The following is a description of a gene set: Genes down-regulated in peripheral blood mononuclear cell 3d vs 0d in adults (18-50) after exposure to Fluarix/Fluvirin, time point 3D. Comment: Supplementary Table 1a: All the differentially expressed genes identified in PBMCs of TIV vaccinees. from publication Nakaya HI, Wrammert J, Lee EK, Racioppi L, Marie-Kunze S, Haining WN, Means AR, Kasturi SP, Khan N, Li GM, McCausland M, Kanchan V, Kokko KE, Li S, Elbein R, Mehta AK, Aderem A, Subbarao K, Ahmed R, Pulendran B (PMID 21743478) species: Homo sapiens Here we have used a systems biology approach to study innate and adaptive responses to vaccination against influenza in humans during three consecutive influenza seasons. We studied healthy adults vaccinated with trivalent inactivated influenza vaccine (TIV) or live attenuated influenza vaccine (LAIV). TIV induced higher antibody titers and more plasmablasts than LAIV did. In subjects vaccinated with TIV, early molecular signatures correlated with and could be used to accurately predict later antibody titers in two independent trials. Notably, expression of the kinase CaMKIV at day 3 was inversely correlated with later antibody titers. Vaccination of CaMKIV-deficient mice with TIV induced enhanced antigen-specific antibody titers, which demonstrated an unappreciated role for CaMKIV in the regulation of antibody responses. Thus, systems approaches can be used to predict immunogenicity and provide new mechanistic insights about vaccines. Human Gene Set: NAKAYA_PBMC_FLUARIX_FLUVIRIN_AGE_18_50YO_3DY_DN, and this is the list of marker genes: RHOH, MYLIP, MSI2, MDH1, SLC2A14, MEF2D, SGSM2, SYTL3, GOLGA8A, CXorf65, ATL2, UBE2B, SELENOK, RNF103, OSER1, RAD23B, BCLAF1, ITPKB, ZBTB25, GOLGA8B, RACK1, ATG16L1, PPP2CA, GORAB, SCAF11, GOLGA6L9, NUP58, CD6, RANBP2, SMURF1, USP15, GNL1, BTG3, BMAL1, ZBTB43, VCPKMT, ILKAP, RGPD8, CDKN1B, PCNX1, RBM25, WDR26, CCNL2, U2AF1, CLK1, RAB11FIP2, COPA, TENT4A, GTF2B, MOAP1, SENP3, ATG2A, CCNL1, ITPR1, PARP8, DIP2B, TASOR2, NOL11, MPHOSPH8, RUNX2, PHF3, FUS, UBAP2L, ZBTB7A, ARID5A, TRIM13, KLHDC2, RGPD5, KANSL2, APBA2, H3-3B, RPAIN, USPL1, DUSP2, SSBP1, DDX51, ANAPC1, RBM19, PABPC1, TNFAIP3, PPP1R16B, DNAJC7, SF3A1, GAS5, RAPGEF2, POLR3E, ZC3H12D, DCAF16, FAM8A1, UNKL, BCL3, SNRPA1, SPRTN, HPS4, HNRNPA3, SRSF1, HNRNPA1, HIF1A, PTPN1, SLC25A36, KRAS, HINT1, BHLHE40, COQ10B, HNRNPH3, PTS, MBD4, LSG1, FASTKD2, PER1, HBP1, MTX3, SFPQ, CHD2, KDM3A, NGDN, SDE2, CYTIP, RBM39, RBM33, PDE4B, SEC31B, SETD1B, ZDBF2, RBM8A (RNA binding motif protein 8A), SFI1, ICOS, HABP4, EIF3B, NUP153, MGAT5, EIF1AD, FAM153CP, PELI1, PTBP2, CIRBP, NLRP1, LUC7L2, PDE7A, DNAJB1, TPM2, TUT4, RICTOR, SLC25A28, CEP95, CDK11A, TAF11, RSRC2 (arginine and serine rich coiled-coil 2), SAR1A, RBBP6, POLR1C, SEPTIN2, PRKCZ, NXT1, TSPYL2, SIAH1, DDX21, ZNF512B, SRSF10, AP3M2, LRP10, ZBTB11, CNOT2 (CCR4-NOT transcription complex subunit 2), PURB, MED23, ELF2 (E74 like ETS transcription factor 2), LINC-PINT, PDCD4, MALSU1, DCP1A, FBXO3, KAT6B, SEC31A, RGCC, ENTPD4, PIM3, TFRC, AKAP17A, ZRANB1, SNORD89, PPTC7, CDC42, NECAP1, FNIP1, TSEN54, YTHDC1, CDC14A, ZBTB5, ZNF529, CYLD, TUFT1, MIR22HG, CDK12, DDX24, MAP4K1, SMPD4 (NCBI Gene Id 94852), AMY1A, SUB1, ZEB1, USP36, SPG7, UBE2A, AKT2, EXOC3, AMY2A (NCBI Gene Id 279), AKAP8, ZFYVE27, WDR33, RCAN3, ZSCAN25, THBD, CTDSPL2, HERC3, GGNBP2, FBXO33, AAK1, ZC3H12A, ASXL1, HSF2, HNRNPD, SUPV3L1, TMEM41B, NDEL1 (nudE neurodevelopment protein 1 like 1), TMEM50B, AMY1B, ZBTB10, IST1, SPOCK2, ZNF639, PLK3, JADE1, ZNF609, PIK3IP1, TRA2A, RNF216, PCBP2, ANKRD10, IL6ST, PSMA3-AS1, PRDM2, FHIP2A, NOP58, RRP1B, RLIM, SERINC1, YTHDF1 (NCBI Gene Id 54915), SLC2A3, RBM14, QSOX2, SLC25A16, HAUS3, SPTAN1, SENP1, PIDD1, MAPK1IP1L, LPIN1, AFF4, STK35, JAK1, BEX2, SMC4, GSPT1, RELL1, ZNF655, ZFAND6, PIGA, IVNS1ABP, EIF2AK3, MARCHF6, CENATAC, ATXN7, LENG8, ARMH1, HNRNPM, SGTB, ANKRD11, KIZ, SIVA1, MTAP, VEGFA, CWC25, OSBP, MFSD14A, JOSD1, CDR2, PHF10, C1orf52, MAFF, IKZF5, CLK4, STMN3, WTAP, JMJD1C, CHD7, ACAP1, DNAJB9, MTCH1, OFD1, UHRF2, DDIT3, OSM, TLE3, RABGGTB, SPTY2D1, AXIN2, AGFG1, TRAPPC10, RRN3P1, IL11RA, ZFAS1, MED26, DDX50, BANP, SNHG1, GMEB2 (glucocorticoid modulatory element binding protein 2), BTG1, ZNF746, PDE4D, PAPOLA, CCDC186 (NCBI Gene Id 55088), JMY, RORA, PPIA, SREK1 (NCBI Gene Id 57833), HECA, GNE, WDR20, PNISR, MED10, EBLN2, NAP1L4, UBALD2, FOXJ3, PPM1A, ZNF274, CLDND1, PSMA3, ARID3B, DGKA, BBX, IGF1R, BRD7, PPIL4, MED6, PNN, USP16, EEIG1, ZNF14, PRP4K, GATA3, PGGHG, SEMA4D, RNF10, CXCR4, NKTR, GPR183, CBX3, MAPK8, AMY1C, SLC6A6, ATXN1L, RPL10, PSMD12, IP6K2, PPM1B, PDZD8, NDUFB8, KDM2A, TNFRSF25, RGPD6, THSD1, PBX4, KLF9, MDM4, SON, RPRD1B, SLCO3A1, NDUFAF5, SNRK, KLHL20, HMGB1, CDK11B, NOL4L, PHF1, STAM, ATP2B1, ZNF430, ILF3, H2AZ2, RYK, QRICH1, USP3, DYNC1LI2, TIPARP, DDX52, PPP2R5C, FAM153A, OGT, GABPB1-IT1 (GABPB1 intronic transcript), DDX47, GOLGA4, HMCES, TMEM59, WHAMM, IFRD1, YRDC, OGA, U2SURP, EIF1, USP21, AP1G1, HIP1R, KDM7A, ZNF880, PGM2L1, CCNT2, HERPUD1, SORL1, SBDS, MDN1, COX4I1, SNRNP200, SOX6, PCNP, NAA16, ITCH, CAPRIN1, RBSN, GPRASP1, SYNCRIP, G0S2, TM2D3